Given this list of marker genes LGALS9C, TSPAN1, PTPRN2, ZG16, ANO7, B3GNT6, SORL1 (NCBI Gene Id 6653), SCNN1A, SPDEF, FER1L6, CHGA, BCAS1, SLC37A1, FAM110C, PLEKHA6, GALNT3, RASEF, SYT7, MUC4 (NCBI Gene Id 55804), MLPH, MAP7, CEACAM5, HLA-F, CAPN8, DHRS9, CLDN8, GPA33, STXBP5-AS1 (NCBI Gene Id 731843), OSBPL7, MUC5B, ENTPD8, PLCD1, UGT2B7, CEACAM6, ERN2, SBNO1, ZMYND8, SLC17A5, ATP2C2, IFI27, SYTL2, here is a description of the gene set: from publication Gao S, Yan L, Wang R, Li J, Yong J, Zhou X, Wei Y, Wu X, Wang X, Fan X, Yan J, Zhi X, Gao Y, Guo H, Jin X, Wang W, Mao Y, Wang F, Wen L, Fu W, Ge H, Qiao J, Tang F (PMID 29802404) Human Gene Set: GAO_LARGE_INTESTINE_24W_C8_GOBLET_CELL species: Homo sapiens